The following is a description of a gene set: species: Mus musculus from publication Chen Y, Wang X (PMID 31504780) Genes predicted to be targets of miRBase v22 microRNA mmu_miR_302b_5p in miRDB v6.0 with MirTarget v4 prediction scores > 80 (high confidence targets). Mouse Gene Set: MIR_302B_5P, and this is the list of marker genes: Pdcd4, Rnf152, Trpc4ap, Tacr2, Plxna2, Gabra4, Resf1, Lrrn1, Rdh14, Tfcp2, Nlk, Moxd1, Snurf, Eea1, Fam210a, Tob1, Tial1, Uri1, Morf4l1, Pptc7, Fut9, Sh3rf1, Sft2d3, Atp2c1, Atp6v1c1, Adgrf5, Otud7b, Itgb1, Gtf2h1, Gm12886, Noa1, Sema5b, Smad3 (NCBI Gene Id 17127), Gad1, Rubcnl, Klhl2, Agfg1, Gm715, Ovol1, Saxo2, Rnf2 (NCBI Gene Id 98537), Bbs5, Braf, Rapgef6, Cdk6, Cnbp, Zeb2, Trmt1l, Ndfip2, Arid4b, Zfand5, Parp11, Trabd2b, Hcfc1r1, Cd2ap, Tbx4, Fbxw11, Kdm7a, Dennd2d, Ints2, 9930111J21Rik2, Sel1l, Fndc3a, Wnt3, Epc2, Zfp397, Prrx1, Arpp19, Coq2, Gbp3, Cpne4, Nbeal1, Smad2, Fcrla (NCBI Gene Id 98752), 1700066M21Rik, Tmeff1, Chst11, Krt12, Kif18a, Med13, Tmed8, Satb1, Ythdc2, Dnal1, Alcam (activated leukocyte cell adhesion molecule), Etv1, Clxn, Tmem185b, Zic3, Fam169a, Fmr1, Dlst, Npat, Chd1, Snrpn, Gtf2a1, Perp, Selenoi, Cxcl2, Slc9a6, Srsf1, Ewsr1, Pak2, Pde5a, Impg1, Dazap1, Spcs2, Smarcad1, Sox6, Pwwp2a, Hcn1, Bicd1, Ilk, Ap3s1, Fbxo45, Hs2st1, Lclat1, Nfrkb, Ppp1ca, Slc12a2, Lrrtm2, Tnrc6c, Msrb3, Dcaf12l2, Pcsk5, Bmp15, Grb2, Exosc9, Aebp2, Ccna2, Rab31, Jmjd1c, Ptprb, Lrrc19, Klra6, Lman1, Cxcl13, Ncl, Gm12185, Snrnp48, Rab14, Smim13, Plagl2, Irs1, Rrp1b, Hdac2, Actr8, Tbx22